The following is a description of a gene set: from publication Chen Y, Wang X (PMID 31504780) Mouse Gene Set: MIR_302D_5P Genes predicted to be targets of miRBase v22 microRNA mmu_miR_302d_5p in miRDB v6.0 with MirTarget v4 prediction scores > 80 (high confidence targets). species: Mus musculus, and this is the list of marker genes: Rrp1b, Msrb3, Tbx22, Gabra4, Tacr2, Pdcd4, Bicd1, Hcn1, Atp2c1, Fbxo45 (F-box protein 45), Lclat1, Impg1, Fam184b, Uri1, Tial1, Selenoi, Hs2st1, Ncl, Wnt3, Rab14, Nfrkb, Hcfc1r1, Gtf2h1, Snrnp48, Chd1, Pptc7, Saxo2, Dazap1, Slc9a6, Smim13, Perp, Parp11, Snrpn, Hdac2, Ovol1, Fmr1, Dennd2d, Braf, Klhl2, Ccna2, Tmeff1, Ythdc2, Prrx1, Cdk6, Rubcnl, Ilk, Irs1 (insulin receptor substrate 1), Sox6, Lrrtm2, Gtf2a1 (NCBI Gene Id 83602), Zic3, Dlst, Dnal1, Ptprb, Rnf2, Cxcl13, Dcaf12l2, Noa1, Tfcp2 (NCBI Gene Id 319662), Resf1, Fam169a, Atp6v1c1, Ndfip2, Tmed8, Slc12a2, Tmem185b, Rdh14, Fndc3a, Gm12185, Lrrn1, Cpne4, Tob1, 1700066M21Rik, Rab31, Aebp2, Pcsk5, Snurf, Zeb2, Coq2, Rnf152, Tnrc6c, Eea1, Fut9, Satb1, Exosc9, Trpc4ap, Itgb1, Lman1, Pak2, Actr8, Krt12, Adgrf5, Gm715, Trabd2b, Gbp3, Alcam, Morf4l1, Agfg1, Grb2, Fcrla, Ppp1ca, Chst11, Arid4b, Klra6, Pde5a, Arpp19, Bmp15, Bbs5, Nlk, Nbeal1, Spcs2, Kif18a, Ap3s1, Rab35, Sel1l, Lrrc19, Tbx4, Zfand5, Sema5b, Gad1, Smarcad1, Otud7b, Plagl2, Rapgef6, Npat, Fbxw11, Cd2ap, Clxn (NCBI Gene Id 74659), Zfp397, Smad3, Cnbp, Plxna2, Cxcl2 (NCBI Gene Id 20310), Jmjd1c, Fam210a, Moxd1, Med13, Ewsr1, Gm12886, Srsf1, Epc2, Kdm7a, Pwwp2a, Etv1, 9930111J21Rik2, Ints2 (integrator complex subunit 2), Trmt1l, Smad2